Given this list of marker genes GLB1, here is a description of the gene set: part of: Mucopolysaccharidoses studied in species Homo sapiens Reactome Pathway: MPS IV - Morquio syndrome B (Keratin metabolism) Defects in beta-galactosidase (GLB1; MIM:611458) can result in GM1 gangliosidosis (GM1; MIM:230500) (not described here), with several phenotypes indicating mental deterioration, as well as in mucopolysaccharidosis IVB, a characteristic mucopolysaccharidosis with no neurological symptoms.<br><br>Mucopolysaccharidosis IVB (MPS IVB, Morquio's syndrome B; MIM:253010) is a rare, autosomal recessive mucopolysaccharide storage disease characterized by intracellular accumulation of keratan sulfate (KS), skeletal dysplasia and corneal clouding. There is no central nervous system involvement, intelligence is normal and there is increased KS excretion in urine (Suzuki et al. "Beta-galactosidase deficiency (beta-galactosidosis): GM1 gangliosidosis and Morquio B disease", p3775-3809 in Stryer et al. 2001). MPSIVB is caused by a defect in betagalactosidase (GLB1), which normally cleaves terminal galactosyl residues from glycosaminoglycans, gangliosides and glycoproteins. The GLB1 gene spans 62.5 kb and contains 16 exons (Oshima et al.1988, Santamaria et al. 2007) and maps to chromosome 3p21.33 (Takano & Yamanouchi 1993).<br>